Given this list of marker genes Slc4a1, Slc4a9, Slc4a10, Slc26a1, Best1, Car4, Slc26a5, Best2, Ptger3 (NCBI Gene Id 19218), Slc4a8, Slc26a7, Slc4a2, Slc4a7, Slc4a3, Cftr, Slc26a3, Slc4a4, Slc4a11, Slc26a6, Slc4a5, Slc39a14, Slc39a8, Slc26a9, here is a description of the gene set: species: Mus musculus Mouse Gene Set: GOBP_BICARBONATE_TRANSPORT The directed movement of bicarbonate into, out of or within a cell, or between cells, by means of some agent such as a transporter or pore.